Given this list of marker genes CARD10, CCR6, LAMP3, CCL19, CCL18 (C-C motif chemokine ligand 18), HSP90B1, CCR4, CARD14, TAP2, IRAK1BP1, FCGR1A, ICOS (NCBI Gene Id 29851), PYCARD, CARD9, IRAK4 (interleukin 1 receptor associated kinase 4), IRAK1, CCR7, CD83, here is a description of the gene set: Genes down-regulated in peripheral blood mononuclear cell 48h vs 0h in adults (22-54) after exposure to F. tularensis vaccine LVS, time point 48H The live vaccine strain (LVS) of Francisella tularensis is the only vaccine against tularemia available for humans, yet its mechanism of protection remains unclear. We probed human immunological responses to LVS vaccination with transcriptome analysis using PBMC samples from volunteers at time points pre- and post-vaccination. Gene modulation was highly uniform across all time points, implying commonality of vaccine responses. Principal components analysis revealed three highly distinct principal groupings: pre-vaccination (-144 h), early (+18 and +48 h), and late post-vaccination (+192 and +336 h). The most significant changes in gene expression occurred at early post-vaccination time points (<=48h), specifically in the induction of pro-inflammatory and innate immunity-related genes. Evidence supporting modulation of innate effector function, specifically antigen processing and presentation by dendritic cells, was especially apparent. Our data indicate that the LVS strain of F. tularensis invokes a strong early response upon vaccination. This pattern of gene regulation may provide insightful information regarding both vaccine efficacy and immunopathogenesis that may provide insight into infection with virulent strains of F. tularensis. Additionally, we obtained valuable information that should prove useful in evaluation of vaccine lots as well as efficacy testing of new anti-F. tularensis vaccines. Human Gene Set: FULLER_PBMC_F_TULARENSIS_VACCINE_LVS_AGE_22_54YO_48HR_DN species: Homo sapiens from publication Fuller CL, Brittingham KC, Porter MW, Hepburn MJ, Petitt PL, Pittman PR, Bavari S (PMID 17349694)